Given this list of marker genes TFDP2, FSIP2, TBR1, SCYL2, BMX, CBX4, ST18, MYRFL, IL23A, GEN1, LEMD2 (NCBI Gene Id 221496), ACE2, FAP, IL1B, FOXN3, ZIC1, GPR3, HOXC4, SLC39A13, BNIP3L, YIPF7, RBM39, PTCH1, AFF3, MITF, SIAH3, LRFN4, MIR22HG, RCAN1, CHEK2, IL10, RORA, C3, GABRA3, PPP1R3D, VIT, KDM4A, ACAA2, CASK, MBNL1, ELMO3, PITX2, PRDM16, PLA2G4A, DCAF6, PDE1B, ACVR2A, KLHL6, WNT10B, MTSS1, EPHA7, PCTP, EPHB6, IRF5, WNK2, SPIB, PRDX4, TNF, TUBA1A, MYH7, S100A8, PDGFC, PLCB1, GPX1, CEPT1, DOCK3, DLX1, ETV1, FLVCR2, JADE2, ABCA6, SFXN4, CHST9, PLCB2 (phospholipase C beta 2), ARPP21, GARS1, MCMBP, TP63, ASCL2, PAX8, LRP1, STC1, IGFBP5, ITGA5, TOB1, ADGRG3, EP300, RGS3, TBC1D10B, KLHL7, AP1G1, NDUFA4L2, ALDOA, MARCKS, EHF, TRIB1, CASQ1 (NCBI Gene Id 844), ZFYVE9, CACNB1, HEXIM2, LARP7, FHIT, TUBB6, RARB, CHD2, FBXW4, DDIT3, ASGR1, FABP4, NSD3, PPP1CB, FAM217B, LRRTM3, SKIDA1, LPO, SMC6, F9, RHOB, CAPN6 (calpain 6), MYH3, DUSP1, SRPK1, S1PR5, LUZP1, AP1S2, SPRY4, GYG1, FOXP2, GYS1 (glycogen synthase 1), ZBTB18, P2RY13, SLC12A1, METTL9, GPR85, CSDE1, PCF11, PLPP5, WNT6, FOXP1 (NCBI Gene Id 87246), PANK3, TBL1X, GLIPR2, SYNCRIP, SLC25A35, IL1F10, ME3, AAR2, SPRR1B, NCKAP5, LMO4, STRN, ITPR3, NRP2, VPS13C, KLK9, PPM1A, CLIP1, CCNL1, RC3H2, ADAMTS5, TNFSF14, SPTLC2, USP9X, ALB, PHOSPHO1, MARVELD1, KCNJ13, PCDHGC3, C2CD2, DSC1, STK39, ITK, ZIC4, PIM1, TBL1Y, CTNNAL1, ACSL5, ERBB4, TPM2, POLG, C1S, AKR1D1, APC, BMF (Bcl2 modifying factor), TNNC2, FAM91A1, MOSPD2, FGF9, SBSN, MAGED2, ANKRD11, NADK, MIDEAS, WDR81, PRKCG, STC2 (NCBI Gene Id 8614), IMPDH1, KLF5, MYH4, TNFSF13B, VAMP3, RGN, PHF21A, COL25A1, CDC42EP3 (CDC42 effector protein 3), FAM53C, BUD31, VNN3P, ERRFI1, FBXW7, RNF17, IL19 (NCBI Gene Id 29949), PTGIR, SFTPD, ECHDC2, TAFA1, H3-3B, CNOT1, EIF4A1, TSPAN5, ACAN, MREG, KRT25, NREP, OTOP3, MBIP, CHAC1, LGALS12, PPL, CFL2, P2RY1, GDPD5, MYBPC1, MAP2K3, RUVBL2, FGF14 (fibroblast growth factor 14), BAHD1 (NCBI Gene Id 22893), SARS1, HOXC10, ETF1, ARID1B, CLN5, MCEMP1, SULF1, CEP41, AMTN, NFATC4, FOXP3, DLG2, SPAG9, ADRB2, FBXL14, DDX47, MTF2, PDAP1, DCN, CSNK1E, PIK3R1, RCOR1, DYRK1A, FLOT2, HOXA5, PCDH8, FAR1 (NCBI Gene Id 84188), GRM7, TFE3, CRIM1, here is a description of the gene set: Genes having at least one occurrence of the motif RNRTKDNGMAAKNN in the regions spanning 4 kb centered on their transcription starting sites. This matches the CEBPB transcription factor binding site V$CEBPB_01 (v7.4 TRANSFAC). Human Gene Set: CEBPB_01 species: Homo sapiens